The following is a description of a gene set: studied in species Homo sapiens Human Gene Set: WP_IMATINIB_AND_CHRONIC_MYELOID_LEUKEMIA Imatinib and chronic myeloid leukemia, and this is the list of marker genes: ABL1, CDKN1B, BCR, KIT, LYL1, GADD45A, MYC, SPRED2, SKP2 (NCBI Gene Id 86997), ABCG2, GAB2, FOXO3, CSF1R, NOP2, FLT1, PIM2, PDGFRA, PDGFRB, PIM1, ABCB1